The following is a description of a gene set: from publication Ji Y, Pos Z, Rao M, Klebanoff CA, Yu Z, Sukumar M, Reger RN, Palmer DC, Borman ZA, Muranski P, Wang E, Schrump DS, Marincola FM, Restifo NP, Gattinoni L (PMID 22057288) species: Homo sapiens Human Gene Set: GSE23568_CTRL_TRANSDUCED_VS_WT_CD8_TCELL_UP Mouse CD8+ T cells affected by ID3 (Inhibitor of DNA binding 3) display patterns of gene expression suggesting enhanced persistance and survival. In this study, we identified genes differentially expressed between ID32a transduced and mock transduced, and ID32a knockout and wild type mouse CD8+ T cells. Most prominent functions of differentially expressed genes include DNA replication-associated repair, maintenance of chromosome stability and mitotic cell divison machinery. Overall, these data suggest that ID3 acts in favor of maintained survival in CD8+ mouse T cells. Genes up-regulated CD8 T cells: mock transduced versus wildtype., and this is the list of marker genes: SLC25A4, PBX3, PPP3CA, GLCE, MTCH1, MARCKS, SAA1, MAP3K8, CD180, TMEM199, ADM, SH3GLB1, IL10RA (interleukin 10 receptor subunit alpha), ANXA1, ARHGAP21, CD37, EIF3J, CBFA2T3, MPEG1 (NCBI Gene Id 219972), CMTM7, S100A10, TIPARP, G6PC3, PDK3, GM2A, EVI2A, PTP4A3, LY6D, KIF16B, LDAF1, WDR55, SLC7A7, ZC3H12C, SLC30A5, IL15, RACGAP1, SLC66A3, S100A6, KCTD12, SCD, ETFB, PAFAH1B3, CXXC5, FCRLA, SBF2, SYK, IL18, CYP4V2, BET1, NDST1, BCL2L2, INPPL1, CD22, CDK2AP1, PSPC1, TPD52, TOR3A, LYL1, CD40, GSTO1, IGHM, ATF6, CEP89, POU2AF1, LIMD1, PEPD, CIITA, MTM1, IQGAP1, PRKCE, RHOQ, ANAPC13, CERS2, CTSZ, CDT1, DNAJB9, CACNA1S, IL4I1, SPIB, MRPL36, NOTCH4, TXNDC16, TCF4, CD79B (NCBI Gene Id 974), CCDC28B, MS4A1, ORC6, PRKCD (protein kinase C delta), MTDH, IL5RA, SLC25A53, CTSE, S100A4, IFI30, EVI5, CTSC, SLC25A15, PKIG, TMEM131, EIF2A, SPSB2, MTPN, CARHSP1, CTSH, EPS8, ANXA7, BLNK, FUCA1, EIF2AK4, NEK2, SNX2, INPP5A, SNX5 (NCBI Gene Id 27131), LMO2, KLF4, ACADL (NCBI Gene Id 33), ADAM9, G6PD, RPIA, RNH1, MPHOSPH10, MCOLN2, PLD4, C15orf39, PLAC8 (placenta associated 8), BLK, GGA2, EBF1, MGST1, ERP29, NCF4, TMOD3, NUCKS1, APOBEC1 (apolipoprotein B mRNA editing enzyme catalytic subunit 1), GPHN, PLP2, PKIB, FCGR2B, RYR1, ANXA2, LMO7, TEP1, GCM2, CCR1, ECI1, NID1, NUCB2, RAB31, GPR137B, ELL2, PARP1, SSPN, TPST1, ALDH2, BTK, PPP3CC, CLIC4, CD2AP, IRF8, MYC, RBM26, PDE8A (NCBI Gene Id 5151), NAP1L1, LGALS3, P2RX4, TMEM176B, HCK, NCF2, LIFR, ERO1B, C9orf85, CD19, TUBB6, NEDD4, PON3, PML, EIF2AK3, BTF3, CXCR5 (NCBI Gene Id 643), CRIP1, EPCAM, CPSF2, PLSCR1, CYFIP1, LAT2, LYN, MYO5A, HHEX, VCL, MYADM, EIF1AY, SYPL1, PLBD1, FGL2, TACSTD2, S100A11, LITAF, MANF, SIRT3, ENTPD1